The following is a description of a gene set: In childhood acute lymphoblastic leukemia (ALL), early response to treatment is a powerful prognostic indicator. To identify genes associated with this response, we analyzed gene expression of diagnostic lymphoblasts from 189 children with ALL and compared the findings with minimal residual disease (MRD) levels on days 19 and 46 of remission induction treatment. After excluding genes associated with genetic subgroups, we identified genes that were significantly associated with MRD. The caspase 8-associated protein 2 (CASP8AP2) gene was studied further because of its reported role in apoptosis and glucocorticoid signaling. In a separate cohort of 99 patients not included in the comparison of gene expression profiles and MRD, low levels of CASP8AP2 expression predicted a lower event-free survival (P =.02) and a higher rate of leukemia relapse (P =.01) and were an independent predictor of outcome. High levels of CASP8AP2 expression were associated with a greater propensity of leukemic lymphoblasts to undergo apoptosis. We conclude that measurement of CASP8AP2 expression at diagnosis offers a means to identify patients whose leukemic cells are highly susceptible to chemotherapy. Therefore, this gene is a strong candidate for inclusion in gene expression arrays specifically designed for leukemia diagnosis. from publication Flotho C, Coustan-Smith E, Pei D, Iwamoto S, Song G, Cheng C, Pui CH, Downing JR, Campana D (PMID 16627760) studied in species Homo sapiens Human Gene Set: FLOTHO_PEDIATRIC_ALL_THERAPY_RESPONSE_UP Up-regulated genes significantly associated with positive minimal residual disease (MRD) on day 46 after chemotherapy treatment of children with acute lymphoblastic leukemia (ALL)., and this is the list of marker genes: RPS19, FAU (FAU ubiquitin like and ribosomal protein S30 fusion), RAB14, RPS28, FXYD5, EIF3D (NCBI Gene Id 8664), IL12RB1, NDRG1, RPL17, CLEC2B, RPS6, ITGA6, EMP1, RPL5, ALX4, KLF10, MACO1, RAB1A, RPS5, CTDSPL, RPLP0, EEF1G, SLC38A2 (solute carrier family 38 member 2), RPL13A, CD69, VAMP3, RPS9, RPL7 (NCBI Gene Id 6129), RPL6, CDC42EP3, RSL24D1, ZDHHC11, RPS16, STAM, AKAP13, EIF4B, RPL22, RPS20, RPL37A, EEF2, SYPL1, OLFML2A, TMED2, MXRA7, TMEM87A, RNF139, RPL27, TOMM20, TPT1, EIF3L, CD34, TBC1D15